The following is a description of a gene set: Human Gene Set: MIR4677_3P studied in species Homo sapiens from publication Chen Y, Wang X (PMID 31504780) Genes predicted to be targets of miRBase v22 microRNA hsa-miR-4677-3p in miRDB v6.0 with MirTarget v4 prediction scores > 80 (high confidence targets)., and this is the list of marker genes: HNRNPU, HEBP1, TNRC6B, TNFSF4, GNAQ, CPA3, CASP14, GMNC, ADAM19, GOLGA6D, TPD52, GLB1, PPP1R12A, TYMSOS, RPRD1A, RAET1E, KLHL14, ARID3B, NRAS, SAYSD1, PTPRO, HSD17B10, CD300A, MACO1, ARHGEF38, CD8B, BBS9, DPH6, CUX1, POPDC2, ZNF22, PALM, RPE, CENPU, GOLGA6C, SOX10, GOLGA8R, IMPG1, RICTOR, AMOTL1, MRPS26, SOX7, GOLGA6B, RB1, DCAF12, GOLGA8Q, HSPA12A, IVNS1ABP, PCDHB14, LDHB, SLC41A2, TBL1X, MECR, JPH3, ZNF737, CHRDL1, NEXMIF, PDE10A, RCAN2, GALK2 (NCBI Gene Id 2585), GOLGA8J, SEC24C, KLF7 (KLF transcription factor 7), ZNF250, GOLGA8N, STARD3NL, CYP7B1, CCDC181, FSHB, GOLGA8T, PTPN1, CNNM4, SIAH1, PDE4D, DUSP18, ESYT2, GOLGA8A, NCOA7 (nuclear receptor coactivator 7), G6PC2, PARM1, SFMBT2, CXXC5, FCRLB, PURB, DAW1, GOLGA8M, GINS2, TP53AIP1, DENND2D, CAVIN2, EP400, WDCP, C1orf141, SOX6, KLK3, ZNF501, PDE4B, PRKCQ, SORBS2, PRKAA2, MRPL19, SGCD, PRSS23, IFNAR1, L3MBTL3, TRIQK, KCNC1, YWHAB, SLC6A6 (solute carrier family 6 member 6), ITGB1BP1, PABIR2, C8orf58, TPPP, ZSCAN16, ZBTB11, RIMS3, CDK8, E2F2, GOLGA6A, CDC23, ABHD14A, RAB1A, ZDHHC7, BPTF, ANKRD62, LCLAT1, UBAC1, YLPM1, GOLGA8H, PLS1, ATL2, ZFHX4, NEDD9, RPGR, NDEL1, PEX11B, RABL6, DCTN6